Given this list of marker genes Zbtb7a, Slc25a5, Kdm1a, Ets1, L3mbtl3, Tgfbr3, Pik3cd, Klf1, Sp3, Sox6, Csf1, Thra, Rps19, Exoc6, Cebpg, Tal1, Lilrb4a, Cd24a, Bbip1, Rps24, Hba-a1, Rcor1, Stat5a (NCBI Gene Id 20850), Fam210b, Mthfd1, Zfpm1, Pknox1, Epas1, Casp3, Trim58, Acvr2a, Ccr2, Acin1, Jmjd6, Cdin1, Pla2g10, Hcls1, Racgap1, B2m, Bcl2l11, Gm15915, Ankrd54, Brd1, Alas1, Inpp5d, Kit, Axin1, Mir451b, Cited2, Hba-x, Foxp3, Hspa9, Hc, Prkdc, Rhd, Ahsp (NCBI Gene Id 170812), Jam3, Hdac6, Klf2, Ldb1, Epo, Fcer1g, Id2, Etv2, Inhba, Zfp36l1, Atp5if1, Zfp36, Anxa1, Bak1, Selenow, Slc25a40, Hamp, Itpkb, Vps13a, Ampd3, Mir451a, Xkr8, Cxcr2, Mafb, Tmem14c, Gfi1b, Dyrk3, Nckap1l, Ypel4, Btk, Prmt1, Hba-a2, Nf1 (NCBI Gene Id 320618), Hnrnpu, Med1, Stat5b, Mapk14, Kat7, Hmox1, G6pdx (NCBI Gene Id 14381), Heatr3, Gcnt4, Cdk6, Klf13, Bcl6, Tmod3, Cdk5rap3 (CDK5 regulatory subunit associated protein 3), Tspan9, Pde4b, Dnase2a, Slc37a4, Il3, Rbfox2, Cd44, Csf1r, Heph, Nemp1, Arid4a, Tcea1, Nfe2l1, Mir122, Traf3ip2, Bap1 (Brca1 associated protein 1), Gpi1, Mir125a, Chmp5, Vegfa, Smad5, Add1, Mir144, P4htm, Ikzf1 (NCBI Gene Id 319751), Mecom, Rac1, Lmo2, Rps14, Slc7a11, Adar, Stat3, Bmp4, Sh2b3, Adgrf4, Rps17, Lyar, Ankle1, Slc15a4, Ehbp1l1, Lyn, Prdx1, Bax, Slc1a5, Ercc2, Slc4a1, Rps6 (NCBI Gene Id 20104, ribosomal protein S6), Itgam, Scnn1b, Adam17, Slc11a2, Setd1a, Jak2, Rac2, Ifng, Uba5, Rb1, Hcar2, Fcgr2b, Smarca4, Fam3d, Bbs4, Axl, Diaph3, Mpl, Hmgb1, Mpig6b, Flvcr1, Hmgb2, Ncapg2, Ptpn2, Smap1, Hmga1, Mertk, Sp1, Hoxa5 (homeobox A5), Rhag, Mfhas1, Glul, Srf, Fech, Myb, Hif1a, Kmt2e, Cfh, Dmtn, Ncstn, Ccl2, Hscb, Mb, Ireb2, Tcf3, Kcnq1, Gata2, Sod1, Alas2 (aminolevulinic acid synthase 2, erythroid), Hoxb6, Hspa1b, Fancc, Isg15 (NCBI Gene Id 53606), G6pd2, Kitl, Slc48a1 (NCBI Gene Id 67739), Plcb1, Acvr1b, Slc25a38, Hbb-bs (hemoglobin, beta adult s chain), Il18, Spi1, Maea, Ptbp3, Tspo2, Ncor1, Trim10, Senp1, Lipa, Bloodlinc (NCBI Gene Id 105463053), Stat1, Adgrf5, Abcb10, Pik3cb, Gata3, Il6, Epb42, Ufl1, Gata1, Foxo3, Bpgm (NCBI Gene Id 97321), Sfxn1, Ank1, here is a description of the gene set: Mouse Gene Set: GOBP_MYELOID_CELL_HOMEOSTASIS studied in species Mus musculus The process of regulating the proliferation and elimination of myeloid cells such that the total number of myeloid cells within a whole or part of an organism is stable over time in the absence of an outside stimulus.